Given this list of marker genes Ccnb1 (cyclin B1), Lmna, Lpin2, Ctdnep1, Lmnb1, Rbm39, Lpin3, Cnep1r1, Prkcb, Emd, Cdk1, here is a description of the gene set: Mouse Gene Set: REACTOME_DEPOLYMERIZATION_OF_THE_NUCLEAR_LAMINA Depolymerization of the Nuclear Lamina studied in species Mus musculus